Given this list of marker genes CHRDL1, CTC1, LRRIQ4, NRK, ALOX15, PCK2, STK39, SLC2A8, TESK2, MYO1E (myosin IE), ALAD, DKKL1, SCUBE3, TUSC3 (NCBI Gene Id 7991), L2HGDH, TMEM247, NRSN1, LLCFC1, ENO3, BPIFB3 (BPI fold containing family B member 3), SECTM1, SLC39A2, KIF18A, ADCY7, FBLN2, GATA3, GLT8D2, INPP1, HAUS3, AVPR1A, KRT16, CTTNBP2NL, FSHR, PCGF5, SOX8, SLCO1B3, GAST, COG3, ALOX15B, MEIG1, HPS4, MND1, XPO7, AIF1L, ACR, TNFRSF4, TBC1D8, C14orf93, TXNRD2, LPIN2, CTNNAL1, ALPI, TTC16, WDR70, TXNL1, MAP3K6, CUL2, GNG12, COL10A1, CROCC, PPIE (peptidylprolyl isomerase E), SERF2, IL20, CCL22, RNF217, ARL6IP1 (NCBI Gene Id 56166, ADP ribosylation factor like GTPase 6 interacting protein 1), SNCAIP, GABRQ, GGCX, PTTG1, ARHGAP19, KRT81, NUB1, HPF1, NMU, TMEM98, P2RY12, UBE2G2, ELF4, HERC1, HSD11B1, PRKCSH, CPA3, RHBG, KRT15, LRTM2, BOC, SLC7A5, NPTX1, GLRA3, SLC5A1, CALCR, SCIN, SLC35D3, ESRRB, LRRC40, TMEM120B, VPS37C, CACNG4, HDAC11, SERPINA4, NDUFA9, ALLC, CENPJ, LYSMD1, MPPED1, EPHA8, VWA3A, PLD4, DBX1, ZNF490, C2CD2, C16orf78, FABP12, HMGCS1, CDC23, ILF3 (NCBI Gene Id 54783), MS4A15, ADORA3, COQ6, LARGE2, NKX1-2 (NCBI Gene Id 414257), GARS1, ANXA13, RAP1A, NFU1, YOD1, IQCA1, QSOX2, OSBPL6, TKT, TMEM129, SCN2A, HSD17B12 (NCBI Gene Id 51144), LCN12, LGR6, IRX1, SEMA6C, C12orf75, CHAC1, TOMM20, CPNE3, STX4, MEMO1, ZDHHC23, ARL6IP6, INAFM1, METTL9, CD22, BMP7, PLEKHG3, HLA-DRB1, MTA1, DCP2, TM4SF5, IFNLR1, PIERCE1, TRIM7, OR51B2, INPPL1, LHFPL4, COL5A1, MORC1, SPSB4, SLC35A1 (solute carrier family 35 member A1), PLCG2, MGAT5B, PHB1, KIF2C (NCBI Gene Id 11004), ASPSCR1, GPR135, VPS37D, TAC1, TRIM9, KLRG1, LIN9, ATP1A2, BIRC2, TTC34, NRCAM, FAM241B, HYAL3, SPATA7, AANAT, HINT1, AFMID, INTS11, DAAM2, TRIM17, DLL4, ATP5F1E, POLD1, LSM4, COL4A6, ZDHHC12, MARS1, GPT2, C1orf56, RASA4, KDM1B, here is a description of the gene set: studied in species Homo sapiens Genes down-regulated in dendiritic cells from speen: conventional versus plasmacytoid. To characterize differences between BALB/c splenic CD11cintB220+Gr1+ PDCs (plasmacytoid dendritic cells), CD11cintB220+CD49b+ IKDCs (interferon producing killer-dendritic cells), and CD11chighB220- cDCs (conventional dendritic cells), we performed gene expression profile analysis using Affymetrix chips. We FACS-sorted BALB/c spleen DC subpopulations. Comparison of differentially expressed genes between IKDCs and cDCs vividly revealed selective expression of multiple NK-related genes in IKDCs. These included granzymes A, B, K and M, perforin, Fas ligand, and NK receptors such as NKG2A, NKG2D, Ly49 family genes, NKR-P1, NKG7, NKp46 and Mafa (KLRG1). No NK-related genes were highly expressed in the PDCs. Human Gene Set: GSE3691_CONVENTIONAL_VS_PLASMACYTOID_DC_SPLEEN_DN from publication Chan CW, Crafton E, Fan HN, Flook J, Yoshimura K, Skarica M, Brockstedt D, Dubensky TW, Stins MF, Lanier LL, Pardoll DM, Housseau F (PMID 16444266)